The following is a description of a gene set: studied in species Homo sapiens The series of molecular signals initiated by a ligand binding to a nucleotide-binding domain, leucine rich repeat containing receptor (NLR), and ending with the regulation of a downstream cellular process. NLRs are cytoplasmic receptors defined by their tripartite domain architecture that contains: a variable C-terminus, a middle nucleotide-binding domain, and a LRR domain that is variable in the repeats composition and number. Human Gene Set: GOBP_NUCLEOTIDE_BINDING_DOMAIN_LEUCINE_RICH_REPEAT_CONTAINING_RECEPTOR_SIGNALING_PATHWAY, and this is the list of marker genes: ITCH, SLC15A3, NOD1, SLC46A2, NAGK, NOD2, BIRC2, RELA, IRGM, CYLD, MAP3K7, MAP2K6, ERBIN, RIPK2, ZNRF4, PTPN22, SLC15A2, HSPA1B, NFKBIA, TLR4, LACC1, BIRC3 (NCBI Gene Id 330), SLC15A4, HSPA1A (NCBI Gene Id 3303), INAVA, RNF34, TNFAIP3, XIAP, OTULIN, IRF5